Given this list of marker genes MAPK3, ALPK1, FOS, FADD, MAPK8, TICAM2, TAB3, MEF2A, NLRX1, DUSP6, NFKBIA, RPS6KA2, UBE2V1, APP, NKIRAS1, MAP3K7, DUSP7, MAPK11 (NCBI Gene Id 5600), TRAF6, CUL1 (NCBI Gene Id 8454, cullin 1), PPP2R5D, RPS6KA3, PPP2R1B, MAP2K1, S100A12, MAPK10 (NCBI Gene Id 5602), MAPKAPK2, NOD2, ATF1, OPTN (optineurin), RPS6KA5, TNIP2 (TNFAIP3 interacting protein 2), UBE2D1, RIPK1, SARM1, UBA52, TLR4, JUN, IRAK1 (interleukin 1 receptor associated kinase 1), RPS6KA1, RIPK3, ATF2 (activating transcription factor 2), MAPK1, CD14, RELA, NKIRAS2 (NCBI Gene Id 55590), ELK1, S100B, NFKB1, RIPK2, CASP8, PTPN11, NOD1, TAB2, DUSP3, MEF2C, TICAM1, UBE2D2, CHUK, MAP3K8, HMGB1, MAP2K6, CREB1, UBE2D3, SKP1, SAA1, USP14, MAPK14, IRF3, BTRC, IRF7, BIRC3, TIFA, TRAF3, IKBIP, PPP2CB, IKBKG, LY96, USP18, UBE2N, TRAF2, MAP2K7, PPP2CA, NFKBIB, TBK1, MAPKAPK3, TP53, MAPK7, MAP2K3, BIRC2, VRK3, IKBKB, LRRC14, DUSP4, UBB (NCBI Gene Id 91253), IRAK2, AGER, TANK, NLRC5, RPS27A, PPP2R1A, FBXW11, MAP2K4, NFKB2, IKBKE, UBC, TAB1, MAPK9, N4BP1, here is a description of the gene set: studied in species Homo sapiens Human Gene Set: REACTOME_MYD88_INDEPENDENT_TLR4_CASCADE MyD88-independent TLR4 cascade